The following is a description of a gene set: Human Gene Set: AATGGAG_MIR136 studied in species Homo sapiens Genes having at least one occurence of the motif AATGGAG in their 3' untranslated region. The motif represents putative target (that is, seed match) of human mature miRNA hsa-miR-136 (v7.1 miRBase)., and this is the list of marker genes: TM9SF3, NPR2, RHCG, SNRK, RADIL, SEPTIN3, PLCXD3, GNG3, SRSF1, ETF1, ICA1 (islet cell autoantigen 1), JAZF1, PSME4, PURB, FMR1, MINK1, INO80, ESRRG, CNOT7, RNF139, ANKRD11, PHF21A, NRK, KCND1, USP37, SGIP1, KDM3A, CBX4, SLC7A3, GRID1, RAP2C, ELK1, RPGRIP1L, GDF6, CPEB2, MTPN, MYOZ1, BPTF, DCAF7, FOXJ3, MDM1 (Mdm1 nuclear protein), TRPC4AP, RGS4, SYDE1, DCDC1, IGFBP5, FAM120A, ZBTB8A, KALRN, RAD51D, TSC22D2, DYRK1A, MOB1B, PATZ1, MLLT11, UBE2G1, GLT6D1, MOSPD1, POP5, ZIC3, SYTL4, PPARGC1A, ZNF710, VCAN, MSL2, ANKZF1, MTMR4, PBRM1, USP25, NONO, EXTL3, NAAA, ZNF148, PPA2, SORCS1, NHSL3, PTPRG, ARID5B, BHLHE22 (NCBI Gene Id 27319), HOXC10